The following is a description of a gene set: Enables the energy-independent facilitated diffusion of a monoatomic cation through a transmembrane aqueous pore or channel. Mouse Gene Set: GOMF_MONOATOMIC_CATION_CHANNEL_ACTIVITY studied in species Mus musculus, and this is the list of marker genes: Kcna10, Dpp6, Scn4a, Nalcn, Cabp2 (calcium binding protein 2), mt-Atp8, Kcnv1, Chrna5, Kcnj12, Cacng5, Rimbp2, Tmem38b, Htr1b, Nedd4l, Kcnv2, Atp5pb, Kcng1, Calhm2 (NCBI Gene Id 72691), Dpp10, Mcoln1, Kcnq3, Kcnk5, Itgav, Gpd1l, Atp5mf, Ptpn3, Psen1, Prkcz, Cacna2d4, Ryr2, Cnga2, Chrna7, Atp5f1c, Lrrc55, Pkd2, Kcnj15, Scn11a, Scn7a, Fxyd4, Atp6-ps (NCBI Gene Id 100503946), Otop3, Fxyd7, Kcnab2, Calhm6, Pacsin3, Kcnj6, Lrrc38, Gpld1, Kcnj14, Ano6, Kcnk4, Kcnd1 (potassium voltage-gated channel, Shal-related family, member 1), Trpc6, Cacng7, Ywhae, Flna, Kcnk10, Itpr1, Kcng4, Atp5pf, Fkbp1b, Kcnk2, Catsper2, Trpc4, Kcnq2, Kcnn4, Cacna1s, Trpc7, Tmem63a, Grin3b (NCBI Gene Id 170483), Faim2, Mcub, Calm3, Asic2, Fgf14, Fxyd2, Tspan13, Kcng3, Amigo1, Trpc1, Kcnh1, Catsper1, Cnga3, Asic5, Cacnb1, Trpa1, Kcnk7, Htr3a, Atp5f1b (NCBI Gene Id 11947, ATP synthase F1 subunit beta), Gria3, Grin2b, Catsper3, Kcnk12, Rem2, Tmprss3, Fxyd3, Scn2b, Kcnf1 (potassium voltage-gated channel, subfamily F, member 1), Cacng6, Slc5a3 (NCBI Gene Id 53881), Kcnq5, Kcnip4 (NCBI Gene Id 80334), Ano10, Kcnc1, Trpv6, Rangrf, Tpcn2, Cngb1, Trpm4, Pkdrej, Scn9a, Kcne4, Catsper4, Chrna6, Chrne, Tmbim6, Cacna1h, Grin2c, P2rx3, Trpm5, Chrna9, Chrnd, Nalf1, Atp5mc1, Itpr2, Atp5me, Abcc8, Panx3, Ghitm, Bnip1 (BCL2/adenovirus E1B interacting protein 1), Mcu, Gria1, Kcnq4, Grik2, Cybb (NCBI Gene Id 97621), Sting1, Cacna2d2, Ncs1, Prss8 (NCBI Gene Id 97375), Calhm5, Adrb2, Kcnu1, Kcna1, Kcne5, Kcns1, Asic4, Grm2, Itpr3, P2rx1, Pias3, Arpp19, Kcnj10, Grm7, Kcnj11, Trpv2, Atp5po (ATP synthase peripheral stalk subunit OSCP), Commd1, Ccdc51, Cav1, Cacna1g, Sgk2, Gnb2, Chrna10, Cacng8, Orai3, Kcnn3, Micu2, Orai1, Prss30, Cacnb2, Snta1, Kcnj9, Pcsk9, Kcnmb4, Kcnab1, Atg5lrt, Lrrc26, Tmem38a, Best2 (NCBI Gene Id 212989), Atp5mg (ATP synthase membrane subunit g), Sumo1, Hcn2, Nedd4, Pkd1l2, Atp2b4, Slc24a5, Scn8a, Kcne1, Pkd1l1, Hcn1, Gem, Atp5f1d, Kcnn2, Kcnn1, Cabp4, Trpm6 (transient receptor potential cation channel, subfamily M, member 6), Trpm7, mt-Atp6, Atp5f1a, Kcnt2, Cacna1b, Scnn1g, Atp5pd, Scn3a, Snap25, Trpc2, Trpm1, Tmem168, Trpc3, Ryr3, Otop2, Kcnk3, Nrxn1, Pkd2l2, Scn2a, Grin3a, Trpv5, Cacnb4, Kcnj2, Pex5l, Kcna7, Trpv1, Dlg1, Cacnb3, Kcnj5, Wnk1, Slc4a11, Micu1, Chrnb1, Trpm2, Chrna2, Cachd1, Phpt1, Hpcal4, Kcnc3, Kcnj1 (NCBI Gene Id 56379), Tmc2, Calhm3, Kcnc2, Scnn1b, Sgk3, Grik3, Grik1, Kcnd2, Kcna5, Cacna2d3, Grik4, Oprm1, Kcnh8, Grm3, Trpv4, Calm2, Kcnj16, Otop1, Cav3, Slc24a1, Calhm1, Kcnk1, Slc24a2, Kcna6, Stim1, Gria2, Agt, Trpm3, Kcnc4, Prkcb, Cabp5, Scn4b, Kcnb2, Tspoap1, Tmbim4, Fxyd1, Nos1, Ywhah, Chrna4, Tmbim1, Hcn4, Fgf11, Cacna1e, Fxyd6, Nalf2, Micu3, Kcna4, Tmem63b, Crisp4, Scn1b, Ano9 (anoctamin 9), Chrnb4, Grin1, Tmem37, Rem1 (NCBI Gene Id 319709), Kcnma1, Chrnb3, Cacng3, Ano1, Slc6a4, Sgk1, Hvcn1, Cnga4, Calm1, Kcnmb1 (NCBI Gene Id 16533), Cacna1f, Kcnh3, Kcnj3, Kcnd3, Kcnip3, Kcnk18, Grin2a, Wnk3, Kcnj8, Prkg1 (protein kinase, cGMP-dependent, type I), Kcnip1, Tmco1, Cacna1c, Piezo2, Sclt1, P2rx5, Scn3b, Chrna1, Hcn3, Cacng4, Cacna2d1, Pde4d, Tmem63c, Kcnmb2, Orai2, Ank2, Aqp1, Cacng1, Kcnk15, Ensa, Kcnk6 (potassium inwardly-rectifying channel, subfamily K, member 6), Tmem109, Kcnk16, Tomm40, Slc24a4, Nrxn3, Chrng, Kcnab3, Akt1, Tpcn1, Cacna1d, Kcnb1, Stx1a, Kcns2, P2rx7, Fgf13, Trpm8, Grik5, Rrad, Scn5a, Kcnh2, Tmc1, Tmem150c, Camk2d, Chrna3, Kcnh6, Pkd1, Atp6v1a, Asic1, Grina, Mcoln3, Lrrc52, Htr3b, Kcnh7 (potassium voltage-gated channel, subfamily H (eag-related), member 7), Mcoln2, Stimate (STIM activating enhancer), Atp5f1e, Cacna1a (NCBI Gene Id 12286), Kcna2, Tnni3, Trpc5, Trpv3, Panx1, Kcna3, Kcnmb3, Kcnj13, Slc30a1, Wnk4, Asic3, Piezo1, Scnn1a, Kcnh4, Kcnh5, Wnk2, Cacng2, Stim2, Chrnb2, Kcnt1, Sec61a1, Rasa3, Tmem175, P2rx6, Kcnj4, Kcnq1, Kcns3, Abcc9, Tmbim7, Glrx, Kcnip2, Cnga1, Akap9, Kcne3, Kcne2, Pkd1l3, Grin2d, Gpm6a, Fgf12, Pkd2l1, Ryr1, Kcnk13, Fxyd5, Scn10a, Unc80, P2rx2, Nrxn2, Cngb3, Kcnk9, Scn1a, Calhm4, P2rx4, Cabp1, Lrg1, Slc24a3, Kcng2, Cacna1i